Given this list of marker genes Trib1, Tgfbr2, Megf10, Dbh, Ccn3, Pde4d, Ctnnbip1, Stat5b, Kcnn4 (potassium intermediate/small conductance calcium-activated channel, subfamily N, member 4), Sulf1, Nox1, Nppc, Ilk, Nog, Hey2, Bmp2, Mapk1, Six5, Fgf9, Nos3, Fos, Hmgcr, Drd4, Ang4, Pdgfd, Zfpm2, Ccnd2, Pak1, Flt1, Ptgis, Notch3, P2ry6, Fgf1, Jarid2, Ccn4, Jun, Gli1, Pdcd4, Cav2, Cyba, Fgf2, Ddit3, Tbx5, Cav1, Pdgfrb, Pik3r1, Gja1, Myd88, Bmp4, Gna12, Ang5, Cnn1, Apc, Mef2c, Myc, Rbm10, Map3k5, Mir1a-2, Ppard, Gnai2, Ski, Ldlrap1, Ager, Cdkn1b, Poldip2, Gnai3, Mir124a-1hg, Il15, Smpd3, Pim1, Timp3, Akirin1, Rbpms2, Mir143, Angpt1, Thbs1, Nf1, Adamts1, Ncam1, Tgfb2, Fgf20, Camk2d, Smad1, Sf1, Sirt1, Tgfb1, Ddr2, Tbx2, Itga2, Ccnb1, Edn1, Apoe, Gper1, Wnt2, Irak1, Pdgfb, Mtor, Rgs5, Ctnnb1, Dnmt1, Klf4 (NCBI Gene Id 269540), Pik3ca, Tenm4, Ereg, Mir133a-2, Irak4, Nol3 (nucleolar protein 3 (apoptosis repressor with CARD domain)), Sod2, Il6, Gata4, Ptafr, Pde1a, Egr1, Igf1, Tnfaip3, Igfbp5, Prkar1a, Yap1, Elane, Gnaq, Jak2, Phb1, Tbx20, Npr3, Nampt, Naa35, Agt, Trp53, Selenon, Mnat1, Il12a, Alox12, Mfn2, Akr1b1, Ptgir (prostaglandin I receptor (IP)), Arid2, Traf6, Stat3, Hpgd, Snhg15, Grk2, Rxra, Mir504, Fes, Hif1a, Igf1r, Xbp1, Pten, Il13, Il6ra, Ednra, Xrcc6, Serpinf2, Ndrg4, Xrcc5, Rps6kb1, Map3k7, Cited2, Sav1, Agtr1a, Abl1, Spon2, Bmpr1a, Hbegf, Myh10, Tgfbr1, Kcnk2, Ephb1, Prkca, Frs2, Bmpr2, Dsn1, Adipoq, Il10, Il12b (interleukin 12b), Cxadr, Rbpj, Ndrg2, Fgfr1, Apod, Hdac2, Mdm2, Aif1, Mir133a-1, Hmox1, Zfp143, Skp2, Erbb4, Fgfr2, Shc1, Vip, Stat1, Comt, Tcf7l2, Npy5r (neuropeptide Y receptor Y5), Src, Nppb, Foxp1, Nrg1, Hes5, Ern1, Apln, Hdac4, Rhoa, Ddx39b, Npr1, Hgf, Tert, Rxrb, Prkdc, Mstn, Gna13, Mapk14 (NCBI Gene Id 26416), 2810429I04Rik, Itgb3, Nr4a3, Ptk2, Id2, Mmp9, Ang, Vgll4, Ptgs2, Mef2d, Foxc2, Calcrl, Gstp1, Shh, Tnf, Tgm2, Myog, Park7, Trp73, Tgfbr3, Rbp4, Egfr, Sugt1 (SGT1, suppressor of G2 allele of SKP1 (S. cerevisiae)), Six1, Ang2, Vegfa, Tbx1, Ace2, Kpna1, Vipr2, Nkx2-5, Rtl1, C3ar1, Efemp2, Esr1, Igfbp3, Ang6, Tafa5, Foxc1, Ifng, Esr2, S1pr2, Retn, Mapk11, Cx3cl1, Tlr4, Orc1, Tgfb3, Mmp2, Mir145a, S1pr1, Gata6, Enpp1, Dyrk1a, Akt1, Ndc80, Myocd, Prkg1, Dipk2a, Paxbp1, Cflar, Cdkn1a (NCBI Gene Id 12575), Gstp2, Tpm1, Ccl5, Cdk1, Myb, Pparg, Bmp10, Foxj2, Gsk3b, Ppargc1a, Nqo2 (N-ribosyldihydronicotinamide quinone reductase 2), Htr1b, Abcc4, Il18, Ogn, Notch1, Tacr1, Cdh13 (NCBI Gene Id 74373), here is a description of the gene set: The expansion of a muscle cell population by cell division. studied in species Mus musculus Mouse Gene Set: GOBP_MUSCLE_CELL_PROLIFERATION